Given this list of marker genes SLC20A2, PRRX1, HIC1, QARS1 (NCBI Gene Id 5859), AP4B1, CEP152, UFC1, PRKN, AMER1, STXBP1, CPSF3, SLC6A9, CYB5A, ABAT, COL4A1, ZNF526, UGP2, DYNC2I2, STAMBP, LSM11, YIF1B, SNORD118, ADARB1 (adenosine deaminase RNA specific B1), SAMHD1, RARS1, HCN1, GNA11 (NCBI Gene Id 93626), VPS50, TET3, NAXD, TMEM106B, MAN2B1, VPS13A, CASR, NOTCH1, EPG5, LMX1B, ATP6AP2, BUB1B, XPR1, TRIP13, GLDC, NR4A2, JAM2, DPYSL5, TRAPPC12, NAXE, PIGQ, HHAT, TMEM147, DLAT, AHI1, MAP1B, DEPDC5, FBP2, DNAL4, DLL4, HK1, PLEKHG2, ARL3, FAM149B1, SDHB, MAST1, USP9X, NEK1, MED23, ZNF423, GJA1, CYP27A1, CDK6, VAC14, HMGCL, NALCN, COG4, CDK5RAP2, NDUFS1, EHMT1, FARSA, NHLRC2, DPF2, WAC, RNASEH2B, SLC44A1, SLC25A22, RB1, PCGF2, RMND1, GLUL, PRR12, SEPSECS, KCTD7, SELENOI, IRF2BPL, NUDT2, MAST3, FANCB, ZNF148, PIGN, FOSL2 (NCBI Gene Id 79579), WDR45, MRPS25, TARS2, GPX4, C2CD3, MTFMT, TEFM, SPG7, DNA2, EIF2S3, SCAF4, DEAF1, TIMM8A, GGT1, SLC25A10, LMNB1, TBCD, JPH3, MCPH1 (microcephalin 1), EXOSC1 (exosome component 1), ALG3, METTL5, EP300, PROP1, SMO, SUOX, NDUFB11, ALG12, NANS, MSTO1, STAT2, SMARCA4, MT-CO2, CENPF, SHH, CELF2, TTI2, IDH1, POLRMT, TCF4, AARS1, GDF1, ARFGEF2, CDK19, KRAS, PHC1, ERLIN2, RXYLT1, GOT2, SMG8, SLC12A6, FDXR, KDM4B, CACNA1A, EML1, FAT4, NARS1, ARMC9 (armadillo repeat containing 9), LONP1, FBXL4, MCM7, BRD4, CUL4B, CRIPT, PPFIBP1, NOTCH3, BCL11B, TRIM8, SPTBN4, DALRD3, KIF15, DHX16, GABRG2, POMGNT1, TIAM1, RNU12, TSEN54, KIF2A, ZBTB18, SH3PXD2B, AQP4 (aquaporin 4), FOXA2, DARS2, POLR1C, KAT5, CTCF, SPG11 (NCBI Gene Id 80208), SLC32A1, UBA5, DNMT1, PEX16, GABRB2, GNPTAB, LRRC32, PIGU (phosphatidylinositol glycan anchor biosynthesis class U), ASXL2, GATA3, PSMB9, PDHB, TYROBP, OCRL, ACTG1, SLC30A9, GPSM2, SNUPN, GON7, CNP, PORCN, ERMARD, MTRR, RPGRIP1, AXIN1, ACTB, WDR73, AMPD2, NSD1, TMEM231, ACOX1, CRIPTO, PTEN, MT-TS2 (mitochondrially encoded tRNA-Ser (AGU/C) 2), ASPM, DAG1, RNF168, ALDH7A1, SLC2A3, FGFR2, VPS16, TBCK, NAA10, FZR1, FCSK, PNKP, RNASET2, BPTF, EPRS1, APC2, CIT, SQSTM1, WBP4, SLC13A5, CTNS, POU1F1, CDK8, DCX, DLL1, BCAS3, DPM2, DNAJC19, GRIA4, MMP23B, ZBTB20, PIK3CA, HCCS, CACNA1I (NCBI Gene Id 8911), MICU1, TBC1D23, NFU1, STUB1, ASXL1 (ASXL transcriptional regulator 1), ACP5, YARS1, PPP1R15B, POLR3GL, MRPS22, SYNE1, GALC, TBX4, NOVA2, AGTPBP1, AARS2, EXTL3, PGAP2, SNX14, RAB34, HACE1, RRM2B, GM2A, SLC46A1, RNF113A, GFER, PI4KA, ZEB2, ERCC8, FGFR1, ZFR, DYNC1I2, L1CAM, KCNB1, PRKCZ, EXOC7, NAA60, LYSET, KMT2D, SHOC2, TSC2, TUBB3, DPAGT1, RFWD3, ZFYVE26, MTRFR, NAA80, SSR4, ERCC3, WDR45B, ATP11A, DVL1, CTSK (cathepsin K), WDR35, NDUFS4, RELN, GAA (alpha glucosidase), MTHFR, KCNT2, NACC1, MED27, NDUFC2, EXOSC3, RPL10, DEGS1, ACO2, DPYS, NR2F1, ASNS, NPHP1, MFF, RNU7-1 (RNA, U7 small nuclear 1), TP73, ARSI, GRIN2D, GRN, KIF26A (NCBI Gene Id 26153), VRK1, PSMB8, KNL1, KCNA1, CSPP1, BRAF, NUS1, CYFIP2, GCH1, DNM1, RUSC2, PHGDH, TBC1D24, REPS1, NCAPD3, MORC2, PSAT1, PPP2R3C, FDFT1, SLC30A10, FRMPD4, CLTC, NMNAT1, MDH2, GPKOW, FLCN, CEP120, ARL13B, POMT2, OSGEP, VARS2, CDK10, DHCR24, DHX9, FRMD4A, SUPT16H, WT1, DDX3X, TACO1, IFT27, BMP4, SRPX2, TBC1D7, ZIC2 (Zic family member 2), KCNT1, HNRNPR, MYT1L, HESX1, COQ4, SUCLA2, MT-TQ, LHX4, RAB23 (NCBI Gene Id 64438), NARS2, THOC2, FGFRL1, SUMF1, ATR, CACNA1E, MECR (mitochondrial trans-2-enoyl-CoA reductase), PPP1R12A (NCBI Gene Id 4659), OSTM1, PPP2CA, KIF14, SCN1B, CA2, CDK13, TOGARAM1, GRIK2, TUBB2B, KCNK4, PLA2G6, KAT6B, CPLANE1, FANCD2, NDUFA9, RBL2, GABRD, IFT140 (intraflagellar transport 140), MT-ND6, ACER3, BCOR, BRAT1, SUGCT, SEC31A, ITPR1, PAFAH1B1, ARID2 (NCBI Gene Id 57676), POLR3B, HUWE1, MT-CYB (NCBI Gene Id 4519), POU3F3, MT-TK, SAMD9L, TMEM107, KIFBP, KCNAB2, MT-ND4, HPDL, KIF5A, RPS6KA3, PRNP, KIDINS220, LMBRD2, BRF1, EXOSC8, SMC1A, ARHGAP31, TUBB2A, PLK4, TSEN2, MPLKIP, TRAPPC11, THOC6, KDM5A, HYLS1, AIFM1, TCTN3, RAB3GAP1, ADCY5, ATG7, SLC35A2, SV2A, AP3B2, RAB11B, ACADS, CNBP, SLC25A15, SLC1A4, DYNC2H1, TSEN15, TMTC3, SMARCC2, PDP1, LAMA2, TAF1, SLC25A4, WDR26, ZNF335, SLC12A2, WWOX (NCBI Gene Id 9621), PDE6D (phosphodiesterase 6D), HECW2, CPLX1, EIF4A2, TK2, PAH, SYNJ1, SLC39A14 (NCBI Gene Id 23516, solute carrier family 39 member 14), ATP6V1A, PNPT1, GAD1, CHMP1A, LUZP1, TRRAP, NODAL, CLP1, RERE, ATXN2, CLN8, TCTN2, PIEZO2, ISCA2, DDHD2 (NCBI Gene Id 23259), SLC9A6, RNU4ATAC (NCBI Gene Id 57788), EXOC8, MRPS16, PRKDC, ASPA, ASXL3, TUBB, UBE4B, HID1, DNM1L, CTBP1, PRMT7, COQ8A, GABRA2, PIGP, KDM5B, FLNA, SALL1, MAN2C1, PDGFRB, COG7, GRIN2A, ATP1A2, ATRX, NEUROD2 (NCBI Gene Id 4761), CILK1, DPM3, KDM3B, SNCA, PPP2R1A, KIAA0753, PRF1, SMARCB1, HEPACAM, SOX4, MT-TL1, ALX4, SLC38A3, CHKA, ALG11, IFT52, CAMSAP1, KIF7, MT-ND1, NDUFA8, RNASEH2C, SIN3A, POLR2A, ANKRD11, CAMK2A, TM4SF20, NDUFAF6, NAE1, LETM1 (NCBI Gene Id 3954), IGBP1, ABHD16A, TGIF1, LMBR1, PIGH, ATP8A2, EXOSC2, SLC12A5, HSPG2, WARS1, UBE2A, PITX1, FRA10AC1, MID1, EIF2B4 (eukaryotic translation initiation factor 2B subunit delta), KARS1, MAPRE2, MOCS1, PIGA, MAF, B4GALNT1, GABBR2, ACTL6B, ERCC1, DDX59, VAMP2, SLC13A3, ALG2, CLCN4, PEX1, KDM6A, DONSON, AMFR, PUM1, TBCE, BLTP1, SLC25A19, ADAT3, RFT1 (NCBI Gene Id 91869, RFT1 homolog), PDSS2, COG3, AUH (NCBI Gene Id 549), AIMP1, GFAP, SIX3, PACS2, B4GAT1, DPH1, COX15, MACF1, ARSA (NCBI Gene Id 410), NDUFAF5, LIPT2, SLC1A2, TMX2, CACNA2D1, GET4, NFIB, ANKLE2, MTHFS, FLI1, FOXH1, SMG9, TPRKB, HNRNPU, SOX2, LAMA1, EXOC2 (exocyst complex component 2), FLVCR2, ERCC6, TWNK, CYP7B1, SCYL2, KATNB1, PAK1 (NCBI Gene Id 5058), SLC6A8, DENND5A, COX7B, ALX1, RAB3GAP2 (NCBI Gene Id 26114), ISG15 (ISG15 ubiquitin like modifier), SNCAIP, GPC4, C12orf57, EIF2AK2, MT-CO3, ARID1A, DYNC1H1, SZT2, POMK, ATP13A2, POLG2, IFIH1, TNR, ACVR1, CMPK2, TMEM165, CDC40, UNC80, GTF2E2, AGO1, ERCC2, TREX1, RHOBTB2, PGAP1, KMT2A, SNAP29, DHDDS, MRPL39, AKT3, CNOT3, RNU4-2, CRLS1, HIVEP2, SATB2, INPP5E, CENPE, DDB1, VAX1, KIF5C, CTNNB1, NEUROG1, ADNP, EARS2, ABCC9, MAP2K2, ATP1A3, AP1S2, PSAP, NSD2, KPNA3, RTTN, SMARCD1 (SWI/SNF related, matrix associated, actin dependent regulator of chromatin, subfamily d, member 1), ITGB6, TBP, CDKL5, PIBF1, THUMPD1, RNASEH2A, PC, CRPPA, SCN1A (NCBI Gene Id 6323), AP5Z1, PEX2, TAF13 (NCBI Gene Id 6884), TMEM237, KMT2E, IBA57, HSPA9, TMEM70, PLPBP, CPT2, RAC1, EMC1, HSD17B4, TMEM138, GPT2 (glutamic--pyruvic transaminase 2), LIG3, SCN8A, CDH2, UPF3B (UPF3B regulator of nonsense mediated mRNA decay), LRP12, CTU2, VPS13B, PTCH1, VCP, CDON, ECHS1, PEX10, TTC5, CCDC88A, ADGRG1, CHMP2B, WNT3, CAMLG, OCA2, FOXP2, SOX11, ENTPD1, B9D1, ALG8, HIBCH, STIL, EBP, TBC1D20, RAP1B, VPS53, SON, YWHAG, RAB18, POLR1A, SLITRK2, GRM7, BSCL2, NTN1, DOCK7, MLC1, PDGFB, GALNT2, SHANK3, GJC2, ATN1, SHMT2, ZDHHC9, EXOSC9, FGFR3 (NCBI Gene Id 55546), SOX10, C19orf12, NSUN3, DYNC2I1, PRORP, SACS, KAT8 (lysine acetyltransferase 8), MTOR, SLC25A1, GLI3, VPS51, IMPDH2, NRCAM, FAM111A, TUBA8, TRMT1, TMEM216, GTPBP3, RBPJ, GABRA5, PPP1R21, SETD2, SF3B2, CC2D2A, PUS3, HTRA2 (HtrA serine peptidase 2), ZNF462, SLC25A46, CDK5, SLC5A6, SLC2A1, OPA1, NTRK2, PIGG (phosphatidylinositol glycan anchor biosynthesis class G (EMM blood group)), SUCLG1, VPS11, MAPKAPK5, KCNA2, PGAP3, LARGE1, TYMP, BUB3, ROBO1, SPEN, NRAS, EOGT, ABCB7, PRPS1, KCNMA1, BCAP31, MMUT, POMGNT2, PMS2, FASTKD2, FANCI, CEP135, UQCC3, RSPRY1, POLG, SLC18A3, SIN3B, PYCR2, CNKSR2, SCN3A, ODC1, MED25, PIK3R2 (NCBI Gene Id 5296), DARS1, B3GALNT2, DNAJB4, TCF12, COG8, PARS2, UBE3C, PUF60, SIK1, PIGB, DCDC2, HNRNPK (heterogeneous nuclear ribonucleoprotein K), ATXN8OS, ABCD1, GBA2, PSMG2, TIMM50, TOE1, POGZ, GMPPB, U2AF2, NSUN2, GAS1, CASK, GOLGA2, UBE3B, AP2M1, AFG2A, GPC3, CEP85L (NCBI Gene Id 387119), DMXL2, COG2, IER3IP1, PDPN, NADK2, ZMIZ1, FGF8, DOHH, PDHA1, RNF13, WLS, TMEM67, FGF12, IVD, SVBP, DIS3L2, RNF220, TAF8, RBBP8, IQSEC2, CDC42, ATPAF2, LHX3, PDHX, SASS6, EDEM3 (NCBI Gene Id 87240), PPP3CA (NCBI Gene Id 5530), GBA1, UNC13D (NCBI Gene Id 201294), GCSH, MT-TT, OTX2, GLRX5, GPRC5B, GRIN1, NELFA, TRAPPC6B, SNF8, ARF1, PPP2R5D, KIAA0586 (NCBI Gene Id 9786), AHSG, LIPT1, MCOLN1, KCNH5, TUBG1, CYB5R3, OTUD7A, CEP63, FARS2, OTUD6B, SIX6, TRPM3, PDE8B, TRAPPC14, ERCC5, MPDZ, ZSWIM6, NKX2-1, CASZ1, DOCK6, FA2H, CLCN3, SMARCE1, MYL9, ALDH6A1, MDH1, KCNC2, POLR3A, H1-4, MPV17, OFD1, PROKR2, UBE3A, DHCR7, NEXMIF, MT-TV, CEP290, CD96, DDX6, EOMES, SLC35B2, FBXO28, MED12, ASL, RIN2, TAF2, DACT1, GATAD2B, ZFX, RBM10, CBS, ACTA2, MAG, SCN2A, HTT, IREB2, GLB1, HRAS, LYRM7, OPHN1, TMEM222, MT-ATP6, AP4S1, ETHE1 (ETHE1 persulfide dioxygenase), RAD51, BRPF1, PLCB4, SETBP1, KMT2B, LEMD2, ATXN3, LIG4, CYP11A1, CNTNAP1, NUP54, AHDC1, NUP188, TARS1, MINPP1, KCNQ2, LSS, TMEM218, GLI2, AP4E1, SLC25A24, MT-TW, CREBBP, NKX6-2, NF1, VARS1, LMNB2, VPS41, KMT2C, RORA, KANSL1, GRIA3, L2HGDH, CFC1 (NCBI Gene Id 55997), ACBD6, MT-ND5, VANGL2, MOGS, UBTF (NCBI Gene Id 7343), ATP9A, HDAC4, VPS4A, HERC1, SYT2, D2HGDH, MEF2C, FH, CCND2, MRPL12, PSEN1, ESAM, GFM1, CNTNAP2, USP7, GTPBP2, HSD17B10, DCC, PI4K2A, CEP57, TXNDC15, FIG4, CNOT1, PTPN23, ZIC1, TRAPPC10, MT-TH, PDYN, ADORA2A, TREM2, CLPB, FBXW11, POMT1, SLC19A3, NDE1, FKTN, PLCB1, TSEN34, FLII, NDUFA6 (NADH:ubiquinone oxidoreductase subunit A6), GNAO1 (NCBI Gene Id 2775), PCLO, HECTD4, RANBP2, RPGRIP1L, WARS2, KDM1A, COPB2, HTRA1, CACNA1G, MAPT, MT-ND3, MBTPS2, CYP2U1, BUB1, FTH1, YY1, NSRP1, NUP37, IGF1R, TRMT10A (NCBI Gene Id 93587), DISP1, GSX2, EIF2B5, GJB1, RALGAPA1, MT-ND2, STRADA, PYCR1, TGFB1, RSPO2, FBXO7, POLR3K, NAGA, C2orf69, EFNB1, CEP41, SMARCA2, NFIA, CWF19L1, ADAR, CARS1, TRAK1, NT5C2, RAC3, GFM2, GNAS, PLCH1, NDUFA2, GLYCTK, AFG2B, UBA1, PDE10A, ARID1B, NDUFB7, HIKESHI, IFT74, NUP62, MYORG, ZNHIT3, STAG2, WDR62, SARS1, IFT80, FTL, PTDSS1, GNB2, INTS11, NFIX, GCDH, PAX6, ALX3, PCNT (NCBI Gene Id 9346), COG5, LAMB1, RECQL4, CCDC47, H3-3A, SUFU, PLP1, SUZ12, PANK2 (NCBI Gene Id 80025), SPTAN1 (spectrin alpha, non-erythrocytic 1), ERCC4, TMCO1, SNIP1, CBY1, DCHS1, STX11, PLXNA1, LNPK, VPS13D, IDS, NECAP1, MYCN, LRPPRC, WDR4, CP, TCTN1, EMX2, TOPORS, YWHAE, GBE1, CCDC174, GTF2H5, PIK3C2A (NCBI Gene Id 5286), SRPK3, CDC42BPB, CARS2, ALDH18A1, ATAD3A, PIGL, MT-TF, SKI (NCBI Gene Id 6497), CTDP1, BICD2, TSC1, STXBP2, FKRP, VWA3B, DPH2, NONO, AHCY, CSF1R, MRAP, AIMP2, MOCS2, TECPR2, PPIL1, HS2ST1, DPYD, TRAPPC9, KIF1C, DIAPH1 (NCBI Gene Id 1729), ARNT2, ARX, MAPK8IP3, CTNNA2, CACNA1B, NRROS, OTUD5, TMEM260, MED12L, B3GLCT, GABRB1, SPG21 (SPG21 abhydrolase domain containing, maspardin), SCO2, ADSL, SOX3, TUBA1A, PRDM16, MFSD2A, LRP2, NEDD4L, COG6, AP1G1, TUBGCP2, FOXG1, MMACHC, SLC4A10, ACY1, DYRK1A, ZNF699, MT-CO1, MKS1, PRUNE1, AP4M1, SYNGAP1, KATNIP, WDR81, LRRK2, RAI1, COASY, CEP104, ATL1, HYCC1, B9D2, USP8, CHD3, EEF1A2, MLH1, PLAA, KCNN2, ADH1C, here is a description of the gene set: Abnormal cerebral subcortex morphology studied in species Homo sapiens An abnormality of the cerebral subcortex. Human Gene Set: HP_ABNORMAL_CEREBRAL_SUBCORTEX_MORPHOLOGY